Given this list of marker genes CWF19L2, XAB2, GCFC2, CWF19L1, YJU2B, TFIP11, ISY1, CRNKL1, CCDC12, DHX15, SYF2, here is a description of the gene set: Human Gene Set: GOCC_POST_MRNA_RELEASE_SPLICEOSOMAL_COMPLEX A spliceosomal complex that is formed following the release of the spliced product from the post-spliceosomal complex and contains the excised intron and three snRNPs, either U2 or U12, U5, and either U6 or U6atac. species: Homo sapiens